Given this list of marker genes EYA3, PTGR2, MTMR11, OSBP, SPECC1L, SYNJ1, REXO4, RGS10, ZNRD2, CEACAM1, PAPOLA, TNFAIP2, UGT1A10, A2M, DESI1, CDK5RAP3, RSPH3, HELLS, JMY, ANTKMT, BCAP31, CXCL13, C4orf54, HSP90B1, PTPRB, PCMTD1, CCDC93, NRIP2, BSCL2, ANAPC5, MMP3, TRPC4AP, COL1A1, HCK, RAMAC, LAMA5, FNDC3A, POLR3K, CSF1, FTH1, ZNF18, C1orf122 (chromosome 1 open reading frame 122), ARRDC1, CCDC124, H4C9, IL18, NPRL3, GZMA, PLOD3, RORA, CSF1R, NXPH3, ARHGDIA, SCNN1A, GLCCI1, COMMD5, MXD4, TSHZ3, CRYZL1, LMNB1 (lamin B1), IFI27, SEMA7A, SENP6, CGRRF1, C17orf100, PPP1R13L, CACNG7, GYG1, STAP2, CXCL16, TIRAP, SAP18, SPRY4, ATP5IF1, DAG1, UGCG (UDP-glucose ceramide glucosyltransferase), ZNF398 (zinc finger protein 398), CNDP2, UQCRH, TRMT13, SOX10, TAC1 (tachykinin precursor 1), MDFIC, TAPBP, ANXA9, GTF2H5, DNAJC13, CPD (NCBI Gene Id 1362), CACHD1, PFKFB4, ACAD11, HPS1, DCAF6, MFSD5, BANF1, SRR, SF3B4, RANBP1, CAST, RENO1, NFKBIZ, ANKHD1, VAT1, S100A1, TLE4, RNF166, ALDH18A1, EIF4E3, PPL (NCBI Gene Id 5493), PRPF39, STC1 (NCBI Gene Id 82914), RBM5, PMP22, COPG1, KIF23, SEC61A2, CSNK1D, PPP1R2, KLHL25, APH1A, POFUT2, DDR2, ZC3H11A, ZEB1, DNPEP, SRSF2, AEBP1, ARMC8, AFG2A, TACSTD2, GALNT1, GFPT2, WSB2, PRKCD, SETMAR, SOCS3, HDAC11, BPHL, here is a description of the gene set: Using a syngeneic p53-null mouse mammary gland tumor model that closely mimics human breast cancer, we have identified, by limiting dilution transplantation and in vitro mammosphere assay, a Lin(-)CD29(H)CD24(H) subpopulation of tumor-initiating cells. Upon subsequent transplantation, this subpopulation generated heterogeneous tumors that displayed properties similar to the primary tumor. Analysis of biomarkers suggests the Lin(-)CD29(H)CD24(H) subpopulation may have arisen from a bipotent mammary progenitor. Differentially expressed genes in the Lin(-)CD29(H)CD24(H) mouse mammary gland tumor-initiating cell population include those involved in DNA damage response and repair, as well as genes involved in epigenetic regulation previously shown to be critical for stem cell self-renewal. These studies provide in vitro and in vivo data that support the cancer stem cell (CSC) hypothesis. Furthermore, this p53-null mouse mammary tumor model may allow us to identify new CSC markers and to test the functional importance of these markers. from publication Zhang M, Behbod F, Atkinson RL, Landis MD, Kittrell F, Edwards D, Medina D, Tsimelzon A, Hilsenbeck S, Green JE, Michalowska AM, Rosen JM (PMID 18559513) species: Mus musculus Genes down-regulated in cancer stem cells isolated from mammary tumors compared to the non-tumorigenic cells. Human Gene Set: ZHANG_BREAST_CANCER_PROGENITORS_DN